The following is a description of a gene set: The asymmetric division of cells to produce two daughter cells with different developmental potentials. It is of fundamental significance for the generation of cell diversity. Human Gene Set: GOBP_ASYMMETRIC_CELL_DIVISION species: Homo sapiens, and this is the list of marker genes: RAB10, POU5F1, ZBTB16, DOCK7, INSC, WNT9B, ING2, ETV5, PARD3, ARHGEF2, GOLGA2, ASPM, PAX6, ACTR3, FGF13, ACTR2, TEAD3, SOX5, RGS14